Given this list of marker genes ADAM10, C11orf24, LUZP1, BICD1, RGS7BP, SLC25A44, NFYB, AFAP1L1, ZNF333, CPEB2, TUBB3, RSPO4, TRAF3 (NCBI Gene Id 7187), SLAIN2, MAP3K7CL, FOXJ2, TMTC2, SOX4, MAZ, LRAT, RAD51, TP53INP1, ABHD13, CEMIP, CSF2RB, FCHSD1, JAG2, TFDP2, RAB11A, MRS2, GLUD1, FNBP1L, ACVR2A, RNF2, SMAD1, CERS6, ELK1, FBXO33, EPHA2, TRPS1, ERBB4, CACNB2, ST7, PEAK1, THUMPD2, MKRN1, SLC35F5, PPP2CA, RAP1A, VTI1A, ELOVL6, FZD7, BICD2 (NCBI Gene Id 23299), MPRIP, PDE6H, C12orf60, PRKD1, MLXIP, AP3B1, RFX4, AMZ1, VCF2, GRM5, FBXL20, RBPMS2 (NCBI Gene Id 348093), SSR3, TNFRSF11B, C16orf87, TECTB, MAGEB6, ZNF202, ZNF426, SEC24B, NUFIP2, CYTH3, UNC5C, SOCS5, PCMTD1, BEX5, ATP5MC3, LRP12, ANKRA2, MAD2L2, AKTIP, PROM2, ZC2HC1A, DEK, HOXC8, CHGB, MBOAT1, DNALI1, TGFBR1, PPP2R2D, RAD51B, SNX12, PLEKHA8, RASL10B, USP15 (ubiquitin specific peptidase 15), SUSD6, LATS2, NFKBIZ, here is a description of the gene set: from publication Chen Y, Wang X (PMID 31504780) studied in species Homo sapiens Human Gene Set: MIR4526 Genes predicted to be targets of miRBase v22 microRNA hsa-miR-4526 in miRDB v6.0 with MirTarget v4 prediction scores > 80 (high confidence targets).